Given this list of marker genes TMED1, PXDC1, ERVW-1, S1PR4, EGF, POU4F1, MAMLD1, FERMT2, ANKRD40, AMOT, SOCS3, NR4A2, NUFIP1, SLC30A4, IRF7, P2RY14, SMPDL3A, OCRL, MMP15, GMDS, HIPK2, CRADD, CASP8, ATG9A, CXCL3, POFUT2, PYROXD1, DHH, PRUNE1, H1-4, MYBPC2, ARPC1A, RFPL1, SCG5, KDM5C, AMPD1, LMO4, MMP10, PVT1, SPAG9, ABCB11, NPY1R, PGM5, ART4, OLFM1, IAPP, BLNK, DLC1, CREB5, MUC1, RBP4, BCL6, PCDH1, NRG2, TFPI2, LGMN, SELP, TRIM21, ARAP1, COL18A1, PBXIP1, CHRNE, GRIK1, MCCC2 (methylcrotonyl-CoA carboxylase subunit 2), HBZ, SHANK2, CCN1, CDIPT, SFRP4, NUCB1, ADGRG2, SERPING1, ZNF592, ANKRD7, JRK, HSD17B3, TGFBRAP1, MINAR1, RFNG (RFNG O-fucosylpeptide 3-beta-N-acetylglucosaminyltransferase), CEP162, GCNT2, IL7R, ST8SIA4, GEMIN4 (NCBI Gene Id 50628), CD38, HSPB2, CACNB2 (NCBI Gene Id 783, calcium voltage-gated channel auxiliary subunit beta 2), ADCY2, CDK5R2, ADAM12, BMP3, TACR1, TTLL5, N4BP2L2-IT2, KLK7, MTIF2, SHROOM2, CTBP2, GAPDH, KRT75, ERN1, LBP, DSG3, CCL13, CD59, PLA2G6, PTPN2, ATP4A, TNFSF8, SYNGR1, MTCP1, GZMK, PRKACA, LRIG1, PAX6, ATP6V1H, CHRND, LAG3, MAP1A, PPFIBP2, ACADS, GADD45B, OVGP1, STX11, NPPA, MYRF, SERPINB8, ITGB6, CNTN6, TNFSF10, LYL1, NAALAD2, TIMM44, RAB3B, SERPINA6, G0S2, ADORA2A, WDR13, ITGB8, SERPINE1, GNG4, FCGR3A, GPX3, PRKCB, ZBTB7B, ZBTB48, SLC6A4, FAM161A, GRK3, CACNB1, GAD2, CFHR4, NFKBIL1, KRT81, KCNQ1, ALDH1L1, DLGAP1, DTNB, DEPP1, TRIM25, BMP5, SLC27A2, RAB29, IFNG, OPHN1, PPP1R3D, ZBTB17, KAZALD1, H2AP, PCDHA9, PROM1, SERPINC1, ENPEP, PSG11, CACNA1S, SREBF2 (NCBI Gene Id 6721), HSD17B1, SLC16A7, LCT, USP8, RLF, SMAD3, HLA-DQB1, CLDN5, NINJ1, SPINT3, VIPR1, NEB, ALG13, ELAVL4, PFKFB1, IGLV3-25, COL4A6, IL33, PLCH2, DEDD, PCNX1, RAD52, CDKN1B, here is a description of the gene set: Human Gene Set: GSE29949_MICROGLIA_VS_DC_BRAIN_DN studied in species Homo sapiens Genes down-regulated in brain: microglia versus dendritic cells. To understand the functional relationship between brain dendritic cells (brain DCs) and other myeloid cells, we compared the gene expression profile of m/chDCs to that of bone marrow monocytes, brain microglia and classical spleen CD8+ and CD8- DCs. In order to obtain enough brain DCs for mRNA extraction, we expanded brain DCs with in vivo Flt3L treatment before purification. from publication Anandasabapathy N, Victora GD, Meredith M, Feder R, Dong B, Kluger C, Yao K, Dustin ML, Nussenzweig MC, Steinman RM, Liu K (PMID 21788405)